The following is a description of a gene set: Human Gene Set: HP_LEUKONYCHIA White discoloration of the nails. species: Homo sapiens Leukonychia, and this is the list of marker genes: PLCD1, GJA1, DSC3, PEX6, CAST, KLK11, GJB2, KIF11, DSP, TRPS1, ABCA12, ATP2A2, KANK2, PEX1